Given this list of marker genes POLA2, PRIM1, POLA1, POLE2, POLE3, POLE, POLE4, PRIM2 (DNA primase subunit 2), here is a description of the gene set: species: Homo sapiens DNA polymerases are not capable of de novo DNA synthesis and require synthesis of a primer, usually by a DNA-dependent RNA polymerase (primase) to begin DNA synthesis. In eukaryotic cells, the primer is synthesized by DNA polymerase alpha:primase. First, the DNA primase portion of this complex synthesizes approximately 6-10 nucleotides of RNA primer and then the DNA polymerase portion synthesizes an additional 20 nucleotides of DNA (Frick & Richardson 2002; Wang et al 1984). part of: Synthesis of DNA Reactome Pathway: DNA replication initiation